The following is a description of a gene set: Human Gene Set: HP_PERIANAL_ABSCESS Perianal abscess The presence of an abscess located around the anus. studied in species Homo sapiens, and this is the list of marker genes: IL10RB, NCF2, RIPK1 (NCBI Gene Id 8737), SEC61A1, TGFB1, MNX1, G6PC3, IKZF3 (NCBI Gene Id 22806), IL10RA, CYBC1, ELANE, MAX, ELF4